The following is a description of a gene set: species: Homo sapiens A process in which a protein is transported to, or maintained in, a location within an early endosome. Human Gene Set: GOBP_PROTEIN_LOCALIZATION_TO_EARLY_ENDOSOME, and this is the list of marker genes: ARL8B, NRP1, EZR, VEGFA, NF2 (NCBI Gene Id 654093), SORL1, EGF, DTX3L, MSN, ROCK2, RDX, MGAT3